Given this list of marker genes HERC5, UBA7, UBE2L6, UBE2E2, ISG15, UBE2E1 (ubiquitin conjugating enzyme E2 E1), here is a description of the gene set: species: Homo sapiens Human Gene Set: GOBP_ISG15_PROTEIN_CONJUGATION The covalent addition to a protein of ISG15, a ubiquitin-like protein.